The following is a description of a gene set: studied in species Mus musculus Mouse Gene Set: REACTOME_INTERLEUKIN_12_SIGNALING Interleukin-12 signaling, and this is the list of marker genes: Il12a, Il12b, Tyk2, Jak2, P4hb, Il12rb1, Il12rb2